Given this list of marker genes Fbrsl1, Mageh1, Adk, Fndc3a, Cnot6l, Azin1, Nr1d2, Daam1, Hmcn1, Nr0b1, Tcf12, Lrrc42, Plscr2, Kdm4c, Mbd4, Il23r, Gad2, Usp25, Gdf3, Ypel5, Ccdc125, Gmfb (glia maturation factor, beta), Nbea, 6030458C11Rik, Rpl10l, Ywhaz, Iars1, Rora, Syt14, Lsm14a, Ggnbp2, Pogz, Wrnip1, Rnft1, Nbeal1, Enpp1, Naa15, Commd2, Ppp4r3c2, Hdgfl3, Cldn8, Lims1, Mybl1, Ppp1r2, here is a description of the gene set: from publication Chen Y, Wang X (PMID 31504780) Genes predicted to be targets of miRBase v22 microRNA mmu_miR_12206_5p in miRDB v6.0 with MirTarget v4 prediction scores > 80 (high confidence targets). Mouse Gene Set: MIR_12206_5P studied in species Mus musculus